Given this list of marker genes Pxn, Pik3r2, Shb, Mapk13, Cav1, Wasf1, Ctnnb1, Ptk2, Jup, Pak3, Hspb1, Pdpk1, Shc2, Ncf1, Hras (NCBI Gene Id 15461), Prkca, Rictor, Mapk12 (NCBI Gene Id 29857), Prkaca, Crk, Cyfip2, Mapk11, Calm1, Mapk14, Cyba, Cdc42, Them4, Vegfa, Vav1, Fyn, Pik3cb, Rasa1, Cdh5 (cadherin 5), Prkacb, Bcar1, Wasf3, Axl, Ncf2, here is a description of the gene set: species: Mus musculus electronically inferred by orthology from the curated human pathway Reactome Pathway: VEGFA-VEGFR2 Pathway This event has been computationally inferred from an event that has been demonstrated in another species.<p>The inference is based on the homology mapping from PANTHER. Briefly, reactions for which all involved PhysicalEntities (in input, output and catalyst) have a mapped orthologue/paralogue (for complexes at least 75% of components must have a mapping) are inferred to the other species. part of: Signaling by VEGF